Given this list of marker genes TNFSF14, CYP2A13, SELENOO, STAT3, MFSD4B, POU2F2, UTP23, SLC13A5, MST1, PLAUR, METTL21A, MARCO, LYN, RGS2, SLC25A37, WARS1 (NCBI Gene Id 7453), GGPS1, FCER1G, LILRB2, ROCK1, TNFRSF1B, MEGF9, MYH11, ITIH3, TYROBP, AIF1, PLIN5, ECHDC2, COTL1, CRP, MAFB, SLC43A2 (NCBI Gene Id 124935), C3orf62, ATP1B3 (ATPase Na+/K+ transporting subunit beta 3), LILRB1, REL, TCF7L2, C5AR1, LRRFIP1, ZMAT3, PELATON, LST1, GADD45B, EFNA1, CD300E, NKTR, VMP1, VSIG1, ITGAX, MS4A7, MLXIPL, CHRD, VCAN, IL6R, MIRLET7BHG, CLEC7A, KCNAB2, TENT5A, ZEB2, NLRP12, CCDC88A, ASPG, FST, GPT2, NTRK3, SHROOM1, BAZ1A, PHF8, ARHGEF10L, C4BPB, JARID2, ACOT9, STK19, DSG3, IL1B, CTSB, LONP2, CYP4F3, SLC11A1, FGR, CTSS, CYP3A5, TLCD2, ZC3H13, S100A11, MT2A, TNRC6A, LUC7L3, FCGR3A, SAMD5, IL1RN, RBM25 (NCBI Gene Id 58517), NSUN6, SAT1, SVOP, LILRB3, DISP2, CYBB, RNF144B, IRAK3, PTK2B, TENM1, APOBEC3A, ZKSCAN1, MPV17L, MDM2, ADAP2, ATP2B1, FCN1, PSAP, EVI2B, ACADVL, NAMPT, SH3BP2, RN7SL510P, CALD1, ACSM2A, PAG1, CYP2B6, H6PD, here is a description of the gene set: species: Homo sapiens from publication Aizarani N, Saviano A, Sagar, Mailly L, Durand S, Herman JS, Pessaux P, Baumert TF, Grün D (PMID 31292543) Human Gene Set: AIZARANI_LIVER_C31_KUPFFER_CELLS_5